Given this list of marker genes MKLN1, SYT17 (NCBI Gene Id 51760), GSG1L, EGF, VAC14, CCDC32, NEU3, DRD2, DNAJC6, ANXA2, VEGFA, CD63, RSPO1, SUSD4, ADIPOQ, SGIP1, APOA5, APLN, SMAP1, WNT3A, WASL, DAB2, VTN, APLNR, DLG4, UNC119, ANXA2P2 (NCBI Gene Id 304), RABGEF1, PPT1, MIR205, EFNB2, UBQLN2, ARRB2, SERPINE1, LDLRAP1, AP2M1, PPP3R1, HPCA, C3, BICD1, MTMR2, PLCG2, H1-1, ANKRD13A, APELA, CCR7, WDR54, USH1G, SYK, TNK2, SH3GL3 (SH3 domain containing GRB2 like 3, endophilin A3), SH3GL2, NTF3, GH1, AAK1, SFRP4, USP6, PCSK9, APOC3, NECAB2, IL4, TBC1D5, LRRTM1, LRPAP1, DRD4, SDCBP, ABCA2, MIR17, ATAD1, TF, HAMP (hepcidin antimicrobial peptide), BMP2K, PICALM, HIP1R, SNAP91, DTNBP1, RALA, APP, USP46, MIR185, DGKD, APOC2, SELE, GREM1, DKK1, OPHN1, APOC1, ITGB3, NCDN (neurochondrin), FMR1, RAC1, AP2A1, PIK3CB, FLOT1, MIR199A1, ATXN2, RIN3, TAMALIN, CCL21, ARC, MIR92B, HFE, ARF6, PICK1, ANGPT1, CLU, ARF1, SCRIB, CCL19, NUMB, ANKRD13D (ankyrin repeat domain 13D), NRG1, CBLB, AHI1, RAB21, MDM2, CBL, RNF220, RABEP1, ARAP1, INSR, B2M, LPAR1, PROM2, LRRTM2, HIP1, ANKRD13B, MAGI2, MIR27B, ARRB1, here is a description of the gene set: species: Homo sapiens Any process that modulates the frequency, rate or extent of receptor mediated endocytosis, the uptake of external materials by cells, utilizing receptors to ensure specificity of transport. Human Gene Set: GOBP_REGULATION_OF_RECEPTOR_MEDIATED_ENDOCYTOSIS